Given this list of marker genes SNRNP35, EWSR1, FCGRT (Fc gamma receptor and transporter), FAM217B, NCBP2AS2, DUSP1, SMIM20, NDUFS2, TESPA1, TBCB, NT5DC1, SMAP1 (NCBI Gene Id 648324), FURIN, SENP7, NUP205, NDUFB2-AS1, HDHD2, MED10, PEX14, MED24, IL12RB2, HACD1, TNFRSF1A, SAFB2, DHFR, PTP4A3, TUBA1B, YWHAH, DNPH1, COX8A, WAS, CMPK1, ESD, UROD, FAM162A, CD101, NSUN5P1, HAUS4, PPA2, MMP24, HEBP2, TMEM143, RIPK3, XRCC1, PPP1CA, PLEKHB1, STIM1, DAZAP2, UBTF, PANX1, ARID1A, CHURC1 (NCBI Gene Id 91612), ATP8B2, DUS3L, NCF2 (NCBI Gene Id 4688), SUN2, CYP4V2, CDK6, SPAG7, EPRS1, LDB1, TMEM116, AKIRIN2, UBE2D3, SHKBP1, CIZ1, MT1HL1 (metallothionein 1H like 1), FBXO4, RBCK1, CERS5, TRMT11, VPS28, TMF1, COMMD1, ZNF395, AFF1, DCAF15, MDM2, KANSL1, GTF2I, CPQ, MINK1, URI1, ROBO3, ELOVL1, HNRNPA2B1, WASF2, NBN, WDR6, PHYKPL, MT2A, USE1 (unconventional SNARE in the ER 1), ERP27, PARVB, REPIN1, IGHD, EOGT, MYBL1, GRK2, BCL2A1, MID2, DHX35 (DEAH-box helicase 35), KLHL6, CBR3, ALKBH6, SMAD2, DPP7, DCPS, FBXL8, ZNF652, ECSIT, DDX17, PDE3B, CARMIL2, ITM2B, COX18, GMEB2, ULK3, TNFRSF18, CXCR6, SMYD2, USP7, C10orf95-AS1, HNRNPU, SMIM19, AK3, TTC39B, EPHA1-AS1, PRKAG2-AS1, PTBP3, ITGAV, APBB1, UBA5, MACROH2A2, UPP1, GGTLC2, TNFAIP8, GGT1, CMTR1, HSD17B11 (NCBI Gene Id 51170), SLC25A15, COMMD4, ACTB, ACE, STAG1, TAOK2, INTS3, MKI67, RABL3, MT1H, VNN2, MIR4435-2HG, SEMA3G, PET117, LMBR1L, PBX3, CMPK2, HAR1A, CCNL1, RNF44, TTC32, CCR8, INO80E, EIF4E3, RILPL2, TLR10, CDC42, BBS2, SEPSECS, SLC46A3, PPP1R9B (protein phosphatase 1 regulatory subunit 9B), EXOSC10, RASSF2, CSDE1, FAM226B, SNX10, HECA, ARHGEF3, ACP6, MPRIP, PPP2R5A, SCCPDH, DYNLL2, PHC1, WNK1, TRABD, SMIM27, PPBP, REC8, RHOF, LRRC41, DPYSL2, PLEKHM2, RNPEPL1 (NCBI Gene Id 58159), NFU1, FAM171A1, SLC35F2, PLIN2, here is a description of the gene set: studied in species Homo sapiens Human Gene Set: GSE2770_TGFB_AND_IL4_ACT_VS_ACT_CD4_TCELL_6H_UP Th1 and Th2 cells arise from a common precursor cell in response to triggering through the TCR and cytokine receptors for IL-12 or IL-4. This leads to activation of complex signaling pathways, which are not known in detail. Disturbances in the balance between type 1 and type 2 responses can lead to certain immune-mediated diseases. Thus, it is important to understand how Th1 and Th2 cells are generated. To clarify the mechanisms as to how IL-12 and IL-4 induce Th1 and Th2 differentiation and how TGF-beta can inhibit this process, we have used oligonucleotide arrays to examine the early polarization of Th1 and Th2 cells in the presence and absence of TGF-beta after 0, 2, 6 and 48 hours of polarization. from publication Lund R, Aittokallio T, Nevalainen O, Lahesmaa R (PMID 14607935) Genes up-regulated in CD4 T cells activated by anti-CD3 and anti-CD28: TGFB1 and IL4 (6h) versus untreated (6h).